Given this list of marker genes IGKV1D-17, CST1, MIA, IGKV1D-13, INAVA, CEACAM1, CXCL9, PSAT1, IGHV3-21, S100A7 (NCBI Gene Id 6278), LTF, FRMPD1, FABP7, GABBR1, PEG10, FYB1, MAGEA3, IGKV3-20, CHAC1, SLPI (secretory leukocyte peptidase inhibitor), SRD5A1, S100A9, HCP5, IGKV1D-39, POPDC3, SIX1, CDH3, HLA-DQB1, CP, BAMBI, S100P, CCL18, here is a description of the gene set: Genes down-regulated in pleura relapse of breast cancer. studied in species Homo sapiens from publication Smid M, Wang Y, Zhang Y, Sieuwerts AM, Yu J, Klijn JG, Foekens JA, Martens JW (PMID 18451135) We explored whether the five previously reported molecular subtypes in breast cancer show a preference for organ-specific relapse and searched for molecular pathways involved. The intrinsic gene list describing the subtypes was used to classify 344 primary breast tumors of lymph node-negative patients. Fisher exact tests were used to determine the association between a tumor subtype and a particular site of distant relapse in these patients who only received local treatment. Modulated genes and pathways were identified in the various groups using Significance Analysis of Microarrays and Global Testing. Bone relapse patients were most abundant in the luminal subtypes but were found less than expected in the basal subtype. The reverse was true for lung and brain relapse patients with the remark that absence of lung relapse was luminal A specific. Finally, a pleura relapse, although rare, was found almost exclusively in both luminal subtypes. Many differentially expressed genes were identified, of which several were in common in a subtype and the site to which the subtype preferentially relapsed. WNT signaling was up-regulated in the basal subtype and in brain-specific relapse, and down-modulated in the luminal B subtype and in bone-specific relapse. Focal adhesion was found up-regulated in the luminal A subtype but down-regulated in lung relapse. The five major molecular subtypes in breast cancer are evidently different with regard to their ability to metastasize to distant organ(s), and share biological features and pathways with their preferred distant metastatic site. Human Gene Set: SMID_BREAST_CANCER_RELAPSE_IN_PLEURA_DN